The following is a description of a gene set: species: Homo sapiens Human Gene Set: GOBP_NEGATIVE_REGULATION_OF_AMINE_TRANSPORT Any process that stops, prevents, or reduces the frequency, rate or extent of the directed movement of amines into, out of or within a cell, or between cells, by means of some agent such as a transporter or pore., and this is the list of marker genes: ABAT, SLC43A2, RGS4, NPY5R, P2RY1, GHSR, CRH, ADRA2B, SNCA, TRH, TNF, PRKG1, SYT11, CHGA, RGS2, ARL6IP5, ADRA2A, DRD2, SLC43A1, GABBR1, GRM7, LEP, SYT4, ADRA2C, ADORA1 (NCBI Gene Id 134)